The following is a description of a gene set: Type I Interferons encompasses a large family of closely related cytokines comprising of at least 13 IFN-α isotypes and single IFN-β. Both IFN-α and IFN-β exert their activity through a common receptor IFNAR. Type I Interferons have broad regulatory effects and various subtypes of dendritic cells are influenced by this cytokines. In our study we asked question whether the low, constitutive levels of type I Interferons produced under steady state conditions are important for proper function of splenic conventional dendritic cells. Human Gene Set: GSE12392_WT_VS_IFNB_KO_CD8A_NEG_SPLEEN_DC_UP studied in species Homo sapiens from publication Zietara N, Łyszkiewicz M, Gekara N, Puchałka J, Dos Santos VA, Hunt CR, Pandita TK, Lienenklaus S, Weiss S (PMID 19581626) Genes up-regulated in CD8A- splenic dendritic cells: wildtype versus IFNB1 knockout mice., and this is the list of marker genes: ITFG2, GLCE, C1orf131, RAB39A, NEK6, ENPP5, GPR4, LMBRD1, ATIC, GFOD1 (NCBI Gene Id 96191), ZNF398, PDLIM7, UQCRB, ZCCHC4, PUM3, FASN, CCNDBP1, NHLRC2, DCTPP1, UNC119, VHL, PLAAT3, TUBB2A, FKBP4, AJUBA, UBTD2, BCL2L14, SGMS1, CISD3, TXNDC16, STARD3NL, ERP44, AKR1A1, CCR9, KCTD6 (NCBI Gene Id 200845), DPAGT1, ELOA, STX3, PPP1R14B, WDFY4, C11orf54, CBR3, HIPK2 (NCBI Gene Id 653052), ADAM19 (ADAM metallopeptidase domain 19), CTDP1, RNF169, DEPDC7, RABGAP1L, PDIA6, SLC25A24, HSD17B13, DUBR, ASAP2, RCBTB2, ASB13, PELO, SDAD1, IGF2R (insulin like growth factor 2 receptor), WASHC5, AP3S1, CPT2, FNIP2, GOLIM4, CPD, ASAH1, LUZP1, POLM, INPP1, RTCB, MYO18A, SSR4, TFDP2, ZNF282, ALMS1, LDHA, LGALS3, CFAP410, KIAA1614, PTCD2, SLC66A2, TCF12, CYTH1, DGKE, AIF1, LITAF, MPV17, GDPD5, ALDH2, VAMP3, RBM17, WDR91, GFUS, TARS3, SLC7A8, DHX35, CASP6, HSD3B7, ADCY4, IL11RA, ACTN1, RUVBL1, C5orf24, GYS1, CCDC90B, TMBIM1, IRF6, MAN1A2, DKK3, ZC3H12C, PPAN, HADH, IGIP, SCARB2, SH3BP4, GSTT2, CTNNBIP1, ACACA, ST8SIA4, REPIN1, MRPL42, SPOP, SLC39A7, USP10, SYNE1, MBOAT1, MAP3K4, ME2, CD1D, IRF5 (NCBI Gene Id 84729), KCTD12, DBI (NCBI Gene Id 1622), TMEM183A, GFM1, OXCT1, FKBP1A, PRDX2, TWSG1, FGD1 (NCBI Gene Id 2245), RIPK3, SLC16A1, ATMIN, PYGO2, NUDT9, PES1, PLEKHB2, SLC26A6, TPST2, SIPA1L1, SYNRG, HMOX1 (heme oxygenase 1), EEFSEC, CAPN2, DOCK7, ALDOA, PPP2R1A, CDC25A, AGPAT3, PMEPA1, ARHGAP42, GTF2E2, ARL6, TOP1, PLXDC1, EXTL3, SH3BP5L, SLC16A6, LRRC14, ITGAL, HTR7, PRDM5, GAMT, GMPR2, ALS2, QSER1, FNDC3B, ANXA7, KIF5A, SAV1, PPA1, GRK5, USP22, ATP5IF1, MYCL, FGD6, COA5, COG2, CYB5A, TRAM2, FOXJ1, CLUH, DLGAP4, GLOD4, C2CD2L, ITPRIPL2, PHB2, NOP2, TSSC4, CKB, MFN1, TAF6L